Given this list of marker genes Ttll1, Folr1, Mapk1, Brpf1, Gabpa, Jag2, Cpt2, Col3a1, Sec24d (NCBI Gene Id 69608), Tbx18, Hyal1, Aldh1a2, Rundc1, Furin, Hey1, Map3k7, Ankrd7, Ifitm1, Tcof1, Nlrp9b, Gata1, Casp3, Sulf1, Traf3ip1, Igf2, Pou5f1, Taf10, Ankrd11 (NCBI Gene Id 78664), Tgif1, Inpp5b (inositol polyphosphate-5-phosphatase B), Wdr83, Dsc3, Arl13b, Hand2, Rpgrip1l, Hoxa7, Dlg1 (NCBI Gene Id 320792), Fbxw8, Fgfr1, Hoxa9, Zbed6, Nckap1, Cdk11b, Rdh10, Tctn1, Pcsk5, Ripply3, Dact1, Tulp3, Nrarp, Synb, Klhl12, Ncor2, Cmip, Slc25a20, Gli3, Med1, Ybx1, Stk4, Wnt3a, Palb2, Hsd17b7, Stox2, Endog, Gdf3, Acsl4, Pitx2, Dscaml1, Exoc3l2, Foxf1, Grn, Mir19a, Arnt, Bcor, Cnot1, Rrn3, Chd8, E2f8, Foxb1, Sema4c, Lias, Ar, Xylt1, Men1, Hoxd1, Myb, Tmed2, Sox11, Hc (NCBI Gene Id 15139), Vcam1, Epn1, Nkx3-1, Itgb1, Hoxb9, Nos3, Gbx2, Colec10, Hoxb3, Dync2i1, Rbp4, Brd4, Socs3, Tead2, Mrtfb, Six4, Elf5, Hinfp, Rpl7l1, Nlrp4f, Rtl1, Ubr3, Adcy9, Srf, Mbtd1, Sdc4, Akirin2, Diaph3, Sox15, Hoxd4, Smo, Dnaaf2, Tcap, Plod3, Suds3, Tfeb, Hs3st6, Slc39a12, Kif3a, Bcl2l1, Nkx2-5, Tgfbr2, C2cd3, Ncor1, Lhx2, Rrp7a, Cert1, Camsap3, Mecom, Wnt5a, Tie1, Slc25a34, Gpi1, Upb1 (ureidopropionase, beta), Nrbp1, Pdzk1, Wdr19, Hoxc4, Slc34a2, Flvcr1, Ascl2, Apba1, Lrp6, Gins1, Lats1, Adm, Akap3, Pax7, Npm2, Psen2, Dlx4, Mir92-1, Man2a1, Ext1, Grhl2, 1700067K01Rik, Ndst1, Apaf1, Sf3b6, Rxra, Kidins220, Mfng, Eif4a3l2, Usp17lc, Acvrl1, Taf8, Rock2, Zfat, Mir127, Plac1, Mks1, Speg, Klf4, Dab2, Prss29, Cts8, Cdkn1a, Ppp2r3a, Stil, Esrrb, Ooep, Kdm6a, Specc1, Tfap2a, Hoxd10, Emg1, Meox2, Bnip2, Trp53bp2, Wnt7b, Megf8, Fxn, Hand1, Ctr9, Ppp1cc, Nek2, Ace, St8sia6, Cebpb, Pitpnb, Hus1, Abi1, Dicer1, Igf1, Cplane2, Akp3, Cdx1, Mybphl, Sall2, Tbx2, Lmo4, Uty, Apba3, Abl2, Mthfr, Angpt1, Hes7, Agbl4, Mtss1, Bysl (NCBI Gene Id 53955), Ccdc62, Brca1, En1, Hoxa11, Esx1, Serpina1b, Tanc2, Plcd1, Syde1, Tet1, Wnt9b, Zic3, Nxn, Trim28, Mafg, E2f7, Col11a1, Hoxb5, Axin1, Nup133, Tbl1xr1, Ccnb1ip1, Cdk20, Sp1, Ifitm5, Maff, Gjb3, Trim71, Pcgf2, Polb (NCBI Gene Id 320892), Mxi1, Ccnb2, Hoxc9, Junb, Pdgfra, Apba2, Nrk, Obox5, Klf1, Rgma, Hnf1a (NCBI Gene Id 21405), Sox8 (NCBI Gene Id 20681), Ttll4, Tab1, Tm4sf1, Hspg2, Ptk7, Add1, Myf5, Cr1l, Foxc1, Abcg2, Lhx1, T, Nsrp1, Gata3, Snai1, Arhgdig, Ric8a, Slit2, Lats2, Il10, Tsc1 (NCBI Gene Id 64930), Ube2a, Hormad1, Ptpn18, Nr5a2, Ror2, Ttbk2, Ly6e, Myo18b, Htt, Smad2, Mir18, Sulf2, Spint2, Gnas, Itgav, Slc39a3, Itga4, Tcf7, Cul3, Plcd3, Gpr161 (NCBI Gene Id 240888), Sall4, Nr2f2, Med21, Otx2, Mir17 (NCBI Gene Id 723905), Ovol2, Csf2, Pth1r, Flcn, Six1, Med12, Pfn1, Zfp36l1, Gas1, Hoxd3, Bcl10, Etl4, Wnt2, Obox8, Mib1, Arnt2, H13, Hcfc1, Sebox, Phgdh, Celsr1, Mnx1, Scx, Lig4, Gata6, Pofut1, Senp2, Prkdc, Dlc1, Brca2, Irx5, Etnk2, Pcdh12, Dzip1l, Mbnl1, Egln1, Alkbh1, Bmp5, Sco2, Sec24b, Sox6, Tbx6, Coq7, Vangl2, Lims1, Kdm4dl, Fendrr, D930028M14Rik, Mmp16, Isl1, Obox3, Syf2, Ctcf, Terf2, Obox1, Gab1, Llgl2, Osr1, Zeb1, Klf2, Cby1, Epb41l5, Fzd6, Hes5, Glmn, Map2k1, Dll1, Hbegf, Bbs4, Slc2a10, Kat2a, Flvcr2, Rbm46, Mgat1, Dusp3, Tgfb2, Pemt, Hs6st1, Npat, Cdk5r1, Padi6, Kif1b, Lif (leukemia inhibitory factor), Pcdha9, Cited1, Ptprr, Notch2, Stk3, Coprs, Col1a1, Ncoa1, Rictor, Cntnap2, Ucma, Hoxb2, Syvn1, Mfn2, Uspl1, Acvr1b, Nipbl, Lef1, Bmpr2, Prrx1, Dvl1, Cthrc1, Luzp1, Ptch1, Nle1, Suv39h1, Pax5, Dkk1, Hoxb4 (NCBI Gene Id 15412), Psmc3, Vezt, Prickle1, Nlrp9a, Keap1, Fkbp10, Ell, Chrd, Adamts3, Nkx3-2, Mir93 (microRNA 93), Txnrd3, Ocrl, Hoxc5, Gorab, Traf6, Hoxb7, Phf6, Btf3, Fbll1, Wnt1, Pdgfrb, G2e3, Zfp420, Meox1, Eno1, Vps54, Celf4, Cited2, Twist2, Shroom3, Cobl, Dnajb6, Ski, Kpna7, Slc30a1, Zbtb18, Cdx2, Myo1e, Hoxa1, Yap1, Svet1, Eif4e2, St14, Emx1, Cdh1, Obox2, Runx1, Setdb1, Myh9, Cops2, Ccnk, Tgfbr3, Hectd1, Gna12, Pbrm1 (polybromo 1), Dlx1, Chd7, Pdcd6, Gcm1, Kdm8, Phlda2, Mesp1, Ppp4r4, Gli2, Chtop, Arhgap35, Vash1, Rarg (retinoic acid receptor, gamma), Xrcc2, Capn2, Smg9, Adam10, Dlx2, Tcf7l2, Dmrt2, Tmem107, Vash2, Rcn1, Birc6, Sox2, Ift140, Xab2, Sfrp2, Sbds, Dlk1, Mthfd1, Cops3, Prkacb, Rbbp6, Gsc, Tmem231, Cripto, Ssr2, Polg2, Scrib, Prkcsh, Myh10, Ripply1, Crb2, Fgf2, Heg1, Rbpj, Zpr1, Smarcb1, Zmiz1, Mthfd1l, Vasp, Dlx3, Rps7, Icmt, Gins4, Ift52, Resp18, Zfp14, Twist1, Dlx5, Zeb2, Tsc2, Kdm4c, Pdgfb, Hoxd11, Msh2, Supt6, Tbx1, Edn1 (endothelin 1), Ccm2, Anks6, 4933434E20Rik, Prss28, Opa1 (OPA1, mitochondrial dynamin like GTPase), Fkbp8, Rnaseh2b, Gata4, Cc2d2a, Trp53, Fosl1 (fos-like antigen 1), Osr2, Rpl13, Hoxa3, Prrx2, Atp1b1, Alx4, Apob (apolipoprotein B), Obox7, Epha2, Cenpu, Hdac3, Zfand5, Dchs1, Bap1, Gjb5, Smarca1, Skil, Smim14, Kdm2b, Specc1l, Ube2b, Vegfa, Nfe2, Cmtm3, Egfr, Tjp1, Hsf1, Dlx6, Rxrb, Otud7b, Rara, Etv2, Zfpm2, Hoxc11, Zfp568, Dll3, Tcf15, Nsdhl, Hif1a, Tent5c, Nasp, Wnt11, Hcn4, Ednra, Hes3, Rnf220, Cfl1, Syna, Sox10, Ift57, Ercc2, Sin3a, Prdm1, Ipmk, 9130008F23Rik, Mmp14, Psmc4, Ep300, Nkx2-6, Ihh, Pax6, Gdf1, Tbc1d32, Ggnbp2, Egfl8, Sufu, Acvr1c, Mafb, B9d1, Tead4, Cebpa, Prmt1, Pelo, Crxos, Sf3b1, Cir1, N4bp2l2, Col2a1, Pax3, mt-Nd4, Dlx1as, Pcdh8, Lrp1b, Pkd2, Chek1, Mosmo, Trip6, Tshz3, Tgfbr1, Rab23, Inka1, Pax1, Kdm2a, Zp3, Setd2, Eif4a3, Tpm1, Mapk8ip3, Tmem100, Foxa1, Ttpa, Krt19, Hoxb8 (NCBI Gene Id 15416), Eif4a3l1, Adgrf4, Hba-a2, Nmt1, Eif2s2, Shox2, Ece1, Obox6, Gse1, Myf6, Msgn1, Prrc2b, Scel, Hopx, Alx3, Fzd3, Cecr2, Fkrp, Plcg1, Polr1b, Cdkn1c, Sec24c, Ripply2, Akt1, 2610005L07Rik, Rtcb, Nbn, Cubn, Sfrp1, Deaf1 (NCBI Gene Id 54006), Fgf8, Dcpp1, Insl3, Erf, Sp3, Tbx3, Pbx1, Slc35e2, Prdm14, Pnldc1, Nlrp9c, Psen1, Rtf1 (RTF1, Paf1/RNA polymerase II complex component), Hhex, Fgf9, Sox9, Atp6ap2 (ATPase, H+ transporting, lysosomal accessory protein 2), Phactr4, Foxd3, Ndel1, Slc39a1, Thoc5, Hsd17b2, Mdfi, Fgfr2, Pef1, Ift172, Cdk2ap1, Foxi3, Ssbp3, Grb2, Ndufa2, Acvr1, Gja1, Slc35d1, Brd2, Ambra1, Fzd5, Plxnb2, Lpar6, Inpp5k (NCBI Gene Id 192772), Matr3, Hnf1b, Abl1, Maf (MAF bZIP transcription factor), Armc5, Spint1, Notch1, Hoxa2, Alx1, Srsf1, Plg, Chst11, Rpa1, Sox18, Hoxa5, C6, Ncoa3, Mesp2, Sh3pxd2a, Ccdc24, Bmp4, Tapt1, Bcl2l11, Gata2, Gna13, Elf3, Poglut1, Rala, Amot, Smad3, Tex19.1, Hoxd9, Hoxc6, Bmi1 (NCBI Gene Id 12151), Oosp1, Ubtfl1, Bmp2, Emp2, Sp2, Cnot2, Rad51b, Dhx35, Nup50, Tgfb3, Zfp335 (NCBI Gene Id 69801), Mycn, Tbx15, Rrm2, Actl6a, Sema3c, Plxna2, Hoxb6, Foxc2, Cdx4, Nop2, Rtn4, Rspo3, Brk1, Hoxb1, Cul4a, Tle6, Lfng, Zfp830, Wnt9a, Ccnb1, Unk, Dbn1, Krt8, Necab1, Psph, Gdf7, Smarca4, Sap130, Runx2, Smpd4, Enah, Nlrp5, Myh6, Ctnnb1, Kat5, Satb2, Mef2c, Cnot3, Atf7, Iws1, Nsun2, Bmp7, Grhl3, Plk4, Evx1, Mir25, Mir20a, Ccn1, Nf1, Acvr2a, Ints1, Atp11a, Gatad2a, Rbbp8, Pcnt, Intu, Kif20b, Pds5a, Fuz, Nodal, Shh, Nolc1, Xrcc4, Wdtc1, Bmpr1a, Sox17, Xist, Hey2, Mir19b-1, Ncoa6, Smad4, Eomes, Pkd1, Dmbt1, Thoc2, Zic5, Slc5a7, Ada (NCBI Gene Id 11486), Usp9x, Ybx3, Sox5, Mir106b, Kbtbd8, Ttn, Msx1, Eya1, Itpk1, Arid1a, Ythdc1, Spic, Casp8, Pax2, Axin2, Ferd3l, Zic2, Epn2, Hoxa6, Ncapg2, Cts7, Dvl2, Hoxa4, Marcks, Six2, Sall1, Meg3, Tfap2c, Foxa2, Kifbp, Asf1b, Epas1, Asxl2, Wdr74, Slc8a1, Hes1, Tgfb1, Prkaca, Grin2b (glutamate receptor, ionotropic, NMDA2B (epsilon 2)), Adgrf5, Cluap1, Dad1, Rmrp, Nog, Zfp42, Upf3a, Atf2, Bptf, Kmt2d, Stmn3, Ift122, Plpp4, Atm, Mbd3, Lrp2, Pramel7, Hba-a1, Wdpcp, Lman1, here is a description of the gene set: Mouse Gene Set: GOBP_EMBRYO_DEVELOPMENT_ENDING_IN_BIRTH_OR_EGG_HATCHING The process whose specific outcome is the progression of an embryo over time, from zygote formation until the end of the embryonic life stage. The end of the embryonic life stage is organism-specific and may be somewhat arbitrary; for mammals it is usually considered to be birth, for insects the hatching of the first instar larva from the eggshell. species: Mus musculus